The following is a description of a gene set: Precise control of transcriptional programmes underlying metazoan development is modulated by enzymatically active co-regulatory complexes, coupled with epigenetic strategies. One thing that remains unclear is how specific members of histone modification enzyme families, such as histone methyltransferases and demethylases, are used in vivo to simultaneously orchestrate distinct developmental gene activation and repression programmes. Here, we report that the histone lysine demethylase, LSD1--a component of the CoREST-CtBP co-repressor complex--is required for late cell-lineage determination and differentiation during pituitary organogenesis. LSD1 seems to act primarily on target gene activation programmes, as well as in gene repression programmes, on the basis of recruitment of distinct LSD1-containing co-activator or co-repressor complexes. LSD1-dependent gene repression programmes can be extended late in development with the induced expression of ZEB1, a Krüppel-like repressor that can act as a molecular beacon for recruitment of the LSD1-containing CoREST-CtBP co-repressor complex, causing repression of an additional cohort of genes, such as Gh, which previously required LSD1 for activation. These findings suggest that temporal patterns of expression of specific components of LSD1 complexes modulate gene regulatory programmes in many mammalian organs. species: Mus musculus from publication Wang J, Scully K, Zhu X, Cai L, Zhang J, Prefontaine GG, Krones A, Ohgi KA, Zhu P, Garcia-Bassets I, Liu F, Taylor H, Lozach J, Jayes FL, Korach KS, Glass CK, Fu XD, Rosenfeld MG (PMID 17392792) Mouse Gene Set: WANG_LSD1_TARGETS_DN Genes down-regulated after Cre-lox knockout of LSD1 in pituitary., and this is the list of marker genes: Btg1, Chga, Chgb, Egr1, Cables1, Cplx2, Syt1 (synaptotagmin I), Dll3, Pcsk1n, Lhb, Syt4, Junb, Snap25, Vegfd, Rims2, Pcsk2, Cish, Ece1, Stxbp1, Cga, Rims3, Egr2, Esm1, Gh, Pclo, Atf5, Tro, Tshb, Chst8, Prl, Gadd45a, Polr3d (polymerase (RNA) III (DNA directed) polypeptide D), Exoc8, Cpe, Ccnb2, Fos, Syn2